Given this list of marker genes Trp53bp2, Mdm2, Smo, Mad1l1, Trp53, Ptch1, here is a description of the gene set: from publication Motenko H, Neuhauser SB, O'Keefe M, Richardson JE (PMID 26092688) species: Mus musculus Mouse genes annotated to increased rhabdomyosarcoma incidence (MP:0002036) retrieved from the Mouse Genome Informatics database via MouseMine Mouse Gene Set: MP_INCREASED_RHABDOMYOSARCOMA_INCIDENCE